Given this list of marker genes Fosb, Hspa1a (NCBI Gene Id 193740), Pmaip1, Pabpc1, Fos, Hspa1b, Zfp36, here is a description of the gene set: from publication Cui A, Huang T, Li S, Ma A, Pérez JL, Sander C, Keskin DB, Wu CJ, Fraenkel E, Hacohen N (PMID 38057668) Cytokines mediate cell-cell communication in the immune system and represent important therapeutic targets. A myriad of studies have highlighted their central role in immune function, yet we lack a global view of the cellular responses of each immune cell type to each cytokine. To address this gap, the authors created the Immune Dictionary, a compendium of single-cell transcriptomic profiles of more than 17 immune cell types in response to each of 86 cytokines (>1,400 cytokine-cell type combinations) in mouse lymph nodes in vivo. A cytokine-centric view of the dictionary revealed that most cytokines induce highly cell-type-specific responses. For example, the inflammatory cytokine interleukin-1β induces distinct gene programmes in almost every cell type. A cell-type-centric view of the dictionary identified more than 66 cytokine-driven cellular polarization states across immune cell types, including previously uncharacterized states such as an interleukin-18-induced polyfunctional natural killer cell state. species: Mus musculus Mouse Gene Set: CUI_CDC2_IL11_RESPONSE_DN Genes negatively differentially expressed in cell type: cDC2 (conventional dendritic cell type 2) upon treatment with cytokine: IL-11 in mouse lymph nodes in vivo.